The following is a description of a gene set: RAC1 GTPase cycle species: Mus musculus Mouse Gene Set: REACTOME_RAC1_GTPASE_CYCLE, and this is the list of marker genes: Rab7, Dock8, Vamp3, Dock1, Dock6, Srgap2, Tfrc, Dock9, Arhgef15, Plekhg2, Cybb, Git2, Arhgap23, Arhgap29, Garre1, Ncf2, Wasf1, Ect2, Mpp7, Lbr, Baiap2, Dock5, Vangl1, Iqgap3, Prex2, Cdc42bpa, Lamtor1, Abl2, Arhgap22, Arhgap30, Kalrn, Nckap1, Wasf3, Arhgap26, Vav1, Pak6, Arhgap25, Dock2, Dock7, Nox1, Erbin, Fam13a, Jag1, Cav1, Nox3, Rac1, Arhgef39, Sos1, Ncf4, Dock10, Arap1, Pkn2, Chn1, Arhgef25, Arhgap15, Plekhg1, Gmip, Cdc42ep4, Arhgap4, Arhgdia, Arhgap31 (NCBI Gene Id 80655), Bcr, Fgd5, Prex1, Ngef (neuronal guanine nucleotide exchange factor), Cyfip1, Pak5, Snap23, Epha2, Abi1, Arhgdib (NCBI Gene Id 11857), Arhgap17, Noxo1, Plekhg6, Srgap1, Als2, Fermt2, Arhgap27, Pak1, Myo9b, Mcam, Ncf1, Trio, Farp1, Arhgap39, Cdc42ep1, Gna13, Rbm39, Arhgap35 (Rho GTPase activating protein 35), Vav2 (vav 2 oncogene), Brk1, Arhgap1, Abr, Nisch, Cyba, Ophn1, Abi2, Mcf2, Vav3, Fmnl1, Pik3r2, Arhgap24, Pard6a, Pik3ca, Cyfip2, Arhgap42, Arap3, Dlc1 (NCBI Gene Id 50768), Ktn1, Git1, Pkn1, Racgap1, Arhgap12, Baiap2l1, Itgb1, Iqgap2, Syde2, Spata13, Arap2, Arhgap5, Chn2, Swap70, Arhgef7, Pik3r1, Arhgap32, Dock4, Pld2, Arhgef18, Arhgap20, Rasgrf2, Vrk2, Farp2, Arhgap44, Nckap1l, Pak2, Pak3, Taok3, Arhgap21, Cdc42, Noxa1, Pak4, Arhgap33, Sos2, Nhs, Plekhg3, Arhgef5, Emd, Def6, Arhgef10, Tiam2, Diaph3, Amigo2, Arhgef6 (Rac/Cdc42 guanine nucleotide exchange factor 6), Arhgap10, Dock11, Esyt1, Mcf2l, Slc1a5, Arhgap45, Sh3bp1, Srgap3, Ykt6, Depdc1b, Arhgef11, Pik3r3, Tagap, Arhgef19, Fam13b, Wasf2, Iqgap1, Ralbp1, Arhgap9